The following is a description of a gene set: studied in species Mus musculus Mouse Gene Set: REACTOME_TRP_CHANNELS TRP channels, and this is the list of marker genes: Trpc4ap, Trpm4, Trpc1, Trpc4, Trpv3, Trpm6, Trpm5, Trpm8, Trpv1, Trpc5, Trpc3, Mcoln3, Trpv5, Trpc6, Trpv6, Mcoln1, Mlkl, Trpa1, Trpm2, Trpm7, Ripk1, Trpc7, Trpm3, Trpv2, Mcoln2, Trpv4, Ripk3, Trpm1